The following is a description of a gene set: Human Gene Set: HP_OMPHALOCELE studied in species Homo sapiens Omphalocele A midline anterior incomplete closure of the abdominal wall in which there is herniation of the abdominal viscera into the base of the abdominal cord., and this is the list of marker genes: TMEM216, HIC1, BHLHA9, LRP2, ISL1, LMOD1, DVL1, RTL1, AR, MASP1, PAFAH1B1, DYNC2H1, FGFR1, FLNA, YWHAE, GAD1, CD96, FOXF1, MYH11, RIPK4, NXN, PTCH1, GRIP1, HYLS1, THRA (thyroid hormone receptor alpha), NUAK2, TSHB, TRRAP, MMP2, IGF2, PIGN (NCBI Gene Id 23556), PLCB4, MAMLD1, GPC3, MBTPS2, SPECC1L, KCNQ1OT1, MKS1, CHD7, CEP120 (centrosomal protein 120), TMEM94, LONP1, MMP14, DVL3, HOXD13, IFT81, IFT80, TWIST2, WDR35, GPC4, MTHFR, ALG9, TTC7A, TP63, SEMA3E, FRAS1, PPP2R3C, FLNB, RAB23, KCNQ1, COL11A2, PORCN, AHDC1, MYLK, PI4KA, NEK9, DLK1, VANGL2, DYNC2I1, FREM2, AMER1 (APC membrane recruitment protein 1), GLI3, DACT1, CDKN1C, CHUK, PPP1R12A, ACTG2, MEG3, MID1, FREM1, NFIX (nuclear factor I X), COL11A1, ZIC3, DYNC2I2